The following is a description of a gene set: species: Homo sapiens Human Gene Set: REACTOME_PEPTIDE_HORMONE_BIOSYNTHESIS Peptide hormone biosynthesis, and this is the list of marker genes: INHBC, CGB5, INHBB, CGA, PCSK1, FSHB, TSHB, INHBE, INHBA, CGB3, POMC, INHA, CGB8, LHB